Given this list of marker genes Ahrr (aryl-hydrocarbon receptor repressor), Scoc, Scel, Ubn1, Gk2, Crybg3, Rtkn2, Ppp2r3a, Krit1, Cecr2, Eif4g2, Zfp36l1, Sebox, Amot, Ugt1a1, Pum2, Hhip, Aebp2, Mapk8, Brwd1, Impact, Trpm7 (transient receptor potential cation channel, subfamily M, member 7), Esco1, Acp1, Ssh2 (NCBI Gene Id 276757), Bmt2, Trim71, Epb41l3 (NCBI Gene Id 56528), Maea, Cp (NCBI Gene Id 51906), Spast, Gucy1a2, Igsf5, Etl4 (NCBI Gene Id 77297), Lrp2, Ube2n, Hdhd2, Ptcd1, Irx5 (Iroquois homeobox 5), Nkx2-2, Lrrc4c, Pof1b, Vps54, Dcaf6, Mcur1, AU018091, Sh2b3, Dcx, Cd69, Ttbk2, Zfp273, Setbp1, Foxj3, Tut4, Kdm3a, Gas6, Kdm4c, Ugt1a9, Atad2b, Garre1, Ugt1a7c, Ugt1a2 (NCBI Gene Id 270363), Ugt1a5, Arhgef3, Rhobtb1, Plscr2, Rasal2, Phip, Spin4, Tmtc1, Nexmif, B3gnt5, Ugt1a10, Or4a73, Ifi204, Ubr3, Rbm5, Ccdc6, Sh3glb1, Tmx3, Tslp, Arpp21, Cacna2d2, Mastl, Fundc2, Pls1, Celsr3, Bnip3l, Fbxo8, Btbd1, Exoc6 (NCBI Gene Id 27365), Npat, Sycp1 (synaptonemal complex protein 1), E130308A19Rik (RIKEN cDNA E130308A19 gene), Bhlhb9, Ano1, Limch1, Glul, Kdelr1, Rbm46, Ccnt2, Bcor, Trio, Ezr, Homer1, Zmat1, Tmem108, Slc22a23, Rai14, Sipa1l2, Eml4 (NCBI Gene Id 78798), Dennd4a, Adra2a, Slco3a1, Arfgef3, Nacc2, Akap7, Xpo7, Ythdc2, Ubr5, Cert1, Nr2f2, Chd1, Ero1a, Rap1a (RAS-related protein 1a), Zic1, Zfp85, Ccsap, Sec24d, Nup54, Pde9a, Hmgcs1, Xrn2, Nkx6-2, Gpbp1l1, Cap1, Dcbld2, Zfp275, Egr3, Mmd, Dagla, Ash1l, Adamts5, Atxn3, Wdr36, Tnrc6a, Oxnad1, Ggnbp2, Zfp865, Gabrb2, Stox2, Wrn, Ranbp3l, Ube2d1, Unkl, Eif4h, Relb, Hdac9, Septin7, Tmprss11d, Cggbp1, Rcc1l, Tomm40, Tnrc6c, Gtf2e2, Unc93b1, Podn (NCBI Gene Id 242608), Tdg, Plagl2, Ugt2b36 (NCBI Gene Id 231396), Atp5f1a, Sim1, Ripor1, Tecpr2, Atp11c, Sos2, Tmem87a, Igfbp7, Nrp1, Aqp8, Sirt4, Rsph4a, Ppp4r1, App, Impa1, Neurod1, Arfgef1, Tra2a, Smurf2, Chd9, Slc30a4, Ppp3cb, Socs6, Magi2, Arid2, Scn1b, Fam210a, Sult1d1, Ano4, Map1b, Rrp15, Pnpla8, Phlpp1, Scai, Gphn, Dtymk, Spata6, Nr1d1, Maco1, Ugt1a6a, Tafa2, Laptm4a, Hipk4, Pcgf6, Pcdh7 (protocadherin 7), Naaladl2, Ppp2r5d, Mcl1 (myeloid cell leukemia sequence 1), Slc38a1, Zmynd8, Lcorl, Irs4, Aff4, Gm715, Crisp1, Epc1, Tmem245, Ptprd, Slc10a7, Slf2, Cog2, Acsl5, Nr0b2, Cd84, Med13, Ocel1, Cotl1, here is a description of the gene set: from publication Chen Y, Wang X (PMID 31504780) Mouse Gene Set: MIR_7660_3P species: Mus musculus Genes predicted to be targets of miRBase v22 microRNA mmu_miR_7660_3p in miRDB v6.0 with MirTarget v4 prediction scores > 80 (high confidence targets).